Given this list of marker genes Mxd1, Cdk6, Saxo2, Tcf12, Zfp820, Ercc6l2 (excision repair cross-complementing rodent repair deficiency, complementation group 6 like 2), Mrpl36, Myl12a, Zbtb5, Nsf, Slc8a1, Atg13, Pogz, Pip4p2, Zfp111, Zfp600 (NCBI Gene Id 667666), Ptgfr, Dcun1d3, Tmem120b, Nras, Zfp947, Donson, Eda2r, Unc5c, Ift57, Mcm6, Serbp1, Cemip, Elovl2, Il18r1, Trim39, Ntrk3, Lmbrd2, Slc24a3, Taf1, Bend6, Synm, Arb2a, Astn1, Cacul1, Zfp980, Crybg3, Dcdc2a, Cdhr1, Usp12, Zc3h13, Trabd2b, Shc4 (SHC (Src homology 2 domain containing) family, member 4), Zfp780b (zinc finger protein 780B), Fzd4, Zfp180, Fitm2, Rc3h1, Fuca2, Slc25a31, D630023F18Rik, Pgrmc2, Capn6, Ralyl, Paxbp1, Cpsf7, Set, Zfp979, Rpl7l1, Gemin8, Ubap1, Smok3b, Tigd4, Ddx3x, Dus1l, Hif1a, Bmp2, Gcnt1, Mllt11, Zxdb, Grip1, Rreb1, Ncapg2, Ahcyl1, Tdpoz1, Cdon, Atf2, Jakmip3, Cdh8, Exoc5, Msantd4, Krt222, Anapc16, Agbl3, Mrpl28, A430005L14Rik, Zfp157, Slc22a6, Tmem169, Kcnma1 (NCBI Gene Id 70528), Elavl4 (NCBI Gene Id 15572), Alcam, Galk2, Mmp15, Dixdc1 (DIX domain containing 1), Zfp994, Pak5, Nufip2, Fam107a, Kalrn, Mcf2l, Tpp2, Cd160, Lhx9, Ttc39b, Ifi27l2b, Sgms2, Zfyve26, Zfp810, Prex1, Plxna4, Sumo1, Septin6, Ankrd40, Ubxn2b, Sertad2, Kat6a, Eqtn, Zfp236, Smim17, Taf12, Tubgcp4, Traf3, Sbspon (somatomedin B and thrombospondin, type 1 domain containing), Hnf4g, Etv1, Pan3, Col24a1, Cmah, Zfp942, Ski (ski sarcoma viral oncogene homolog (avian)), Hspd1, Cabcoco1, Htr5a, Arfgef2, Ilf3, Smok3a, Kansl1, Ica1l, Efcab11, Zfp995, Slc38a2, Ctnnd2, Neurod4, Mat2a, Tent5a, Fancl, here is a description of the gene set: from publication Chen Y, Wang X (PMID 31504780) studied in species Mus musculus Genes predicted to be targets of miRBase v22 microRNA mmu_miR_1896 in miRDB v6.0 with MirTarget v4 prediction scores > 80 (high confidence targets). Mouse Gene Set: MIR_1896